Given this list of marker genes Dync2i1, Col1a1, Ccn3, Hapln3, Barx2 (NCBI Gene Id 69472), Bglap, Pax7, Zfp219, Runx2, Ddrgk1, Idua, Nfia, Ext1, Fgr, Slc39a3, Evc, Col3a1, Trip11, Frem1, Mdfi, Mkks, Chadl (chondroadherin-like), Wnt2b, Rarb, Comp, Col5a2, Dll3, Hoxa11, Gdf2, Tulp3, Myf5, Col2a1, Cytl1, Hmga2, Mia3, Anxa2, Rara, Thbs1, Cdx1 (NCBI Gene Id 12590), Hoxb3, Axin1, Il17f, Fst, Cldn18, Hotair (NCBI Gene Id 100503872), Gli3, Pth, Slc9b2, Hoxa10, Cbs, Pappa2, Hapln4, Tgfb1, Hoxa1, Ptger4, Chad, Bglap2, Sgpl1, Eya1, Ggcx, Dlx1, Ski, Chrdl2, Pth1r, Bmpr2, Gpr68, Efemp1, Msx1, Hexb, Ppargc1b, Smad3, Thra, Pbxip1, Nipbl, Pdgfa, Sbds, Schip1, Plxnb1, Atg9a, Srf, Kat2a, Foxn3, Hoxd3, Osr1, Ift25, Creb3l2, Opa3, Bmpr1a, Six2, Mir188, Norad (non-coding RNA activated by DNA damage), Lipa, Thrb, Siglec15, Cer1, T, Ddr2, Sp3, Prrx1, Cyp26b1, Ihh, Atp6ap1, Ccn1, Adamts7, Lep, Nodal, Bmncr, Ltbp3, Men1, Lrrk1, Pbx1, Ebp, Rbp4, Nfib, Fgfrl1, Glg1, Trpv4, Ranbp3l, Rab33b, Ptprc, Wnt9b, Hdac4, Nfix, Itgb6, Gnaq, Recql4, Dscaml1, Obox2, Sik3, Ash1l, Wnt5a, Rflnb, Shox2, Slc39a14, Fmn1, Satb2, Arid5a, Map2k6, Hoxc8, Ncan, Alx4, Sulf2, Tapt1, Stc1, Snx19, Sema4d, Prkg2, Sh3pxd2b, Hoxb4 (homeobox B4), Hoxb9, Tbx3, Deaf1, Bbs2, Wfikkn1, Hyal1, Hoxb8, Ccn2, Flvcr1, Frzb (NCBI Gene Id 20378), Pitx1, Smad5, Fgfr1, Timp3, Hoxd12, Rpl13-ps6, Fgfr3, Hoxd11, Sulf1, P2rx7, Rdh10, Slc39a1, Prrx2, Fosl2, Osr2, Sfrp1, Etl4, Lrrc17, Nr5a2, Hspg2, Nle1, Rpl38 (ribosomal protein L38), Npr2, Papss2, Cyp27b1, Mapk11, Zic1, Ripply1, Myc, Psen1, Timp1, Lnpk, Hes5, Mapk14, Hsd17b7, Myoc, Hoxb2, Dlx5, Slc38a10, Rassf2, Bbx, Cnmd, Tmem38b, Tle5, Chst11, Mapk3, Foxc1, Tbx15, Bbln, Mmp2, Insig2, Dchs1, Mks1, Hoxd8, Zmpste24, Sfrp2, Setdb1, Gna11, Mir140, Hoxa2 (homeobox A2), Tnfsf11, Akap13, Ppib, Clec3b, Fgf8, Tfap2a, Fbxw7, Prpsap2, Col1a2, Col6a1, Pax1, Hoxa6, Eif4a3l2, Sox11, Tgfbi, Alpl, Mboat2, Gdf5, Dhrs3, Bmp1, Mef2d, Obox3, Trp53, Hexa, Pkdcc, Tgfbr1, Spef2, Nppc, Hoxc9, Chaserr, Rgn, Smad2, Nkx3-2, Mepe, Sox9, Trim45, Notum, Lama5, Sox6, Chd7, Rflna, Hoxc11 (NCBI Gene Id 239679), Arid5b, Lncpint, Tmem119, Fbn2, Tyms, Mmp14, Nog, Hoxa5, Tgfb2, Mycn, Fuz, Lrp5, Errfi1, Ctc1, Scube2, Snai2, Bmp8b, Cst5, Acvr2a, Obox1, Med12, Npr3 (natriuretic peptide receptor 3), Ctnnb1, Bmp7, Lrp6, Miga2, Esrra, Acan, Fgf4, Tgfb3, Ift80, Smad7, Trappc2, Wfikkn2, Rarg, Actn3, Usp1, Gli2, Dym, Lepr, Inppl1, Hoxd1 (homeobox D1), Vdr, Has2, Spns2, Ryk, Poc1a, Snai1, Kdr, Ifitm5, Gpld1, Foxc2, Prkca, Chrd, Serpinh1, Obox8, Gnas, Alx3, Ryr1, Zfp950, Tifab, Sp5, Notch2, Xylt1, Hyal3, Bpnt2, Col27a1, Dicer1, Atg9b, Gdf11, Tgfbr2, Ndst1, Cr2, Mosmo, Zic3, Asxl1, Thbs3, Tnn, Fgf6, Pafah1b1, Bcan (brevican), Cadm1, Trp63, Mdk (midkine), Csgalnact1, Dlx1as, Gdf6, Setd2, Bmp2, Wnt7b, Epyc, Wnt9a, Tcf15, Ext2, Slc26a2, Rhoa, Csrnp1, Rpl13, Wnt7a (wingless-type MMTV integration site family, member 7A), Jag2, Loxl2, Ctsk (NCBI Gene Id 99590), Mmp16, Matn3, Dspp, Mef2c, Mcph1 (microcephaly, primary autosomal recessive 1), Fat4, Hoxb5, Pdgfc, Mgp, Fgf2, Tiparp, Obox7, Wnt10b, Slc2a10, Rela, Hif1a, Snx10, Hhip, Ogn, Fbln5, Uncx, Acd, Ltf, Smpd3, Twist2, Col13a1, Mbtd1, Hand2, Grem1, Acp5, Map3k7, Bmp4, Hes7, Ninj1, Pkd1, Ccdc154, Ankrd11, Fam20c, Ostn, Tmem107, Chsy1, Bnc2, Alx1, Cacna1s, Bmp10 (NCBI Gene Id 12154), Ift140, Col18a1, Shh, Acvr2b, Vkorc1, Ghrl, Fgfr2, Dlx2 (NCBI Gene Id 99330), Itgb8, Pls3, Axin2, Enpp1, Plekha1, Dnm3os, Phospho1, Sp1, Zfand5, Cdk20, Mthfd1l, Fancb, Scin, Twist1, Sparc, Pum2, Cited2, Ptpn11, Ano6, Ednra, Col10a1, Hoxa9, Bglap3, Nfatc2, Mex3c, Col11a2, Zbtb7a, Bmpr1b, Hoxc6, Hyal2, Wnt1, Hoxa3, Phex, Wwox, Hapln2, Hapln1, Trps1, Rb1, Wdr48, Bmi1, Dlx4, Ucma, Cdkn1c, Col9a1, Fgf18, Dmd, Otor, Insig1, Lhx1, Fbn1, Hoxd4, Serp1, Hsd17b1, Smad1, Megf8, Bmp3, Atp7a, Gja1, Ecm1, Rab23, Bmp8a, Gas5, Matn1, Six1, Sfrp4, Mbtps2, Hoxd10, Tjp2, Zbtb16, Large1, Dmrt2, Galnt3 (polypeptide N-acetylgalactosaminyltransferase 3), Lgals3, Edn1, Gsc, Foxp1, Hoxb6, Ror2, Bbs1, Pds5a, Gas1, Atf2, Ripply2, Hoxa4, Zfp640, Ift172, Pthlh, Hoxb1, Prkra, Lox, Eif4a3, Slc35d1, Neurog1, Maf, Smad9 (SMAD family member 9), Obox5, Srd5a2, Src, Eng, Gdf3 (growth differentiation factor 3), Ep300, P3h1, Amer1, Slc10a7, Bgn, Optc, Dlx6, Pcgf2 (polycomb group ring finger 2), Hoxc4, Dlk1, Tyrobp, Vcan, Rspo2, Pdgfrb, Igf1, Mir2861, Asxl2 (ASXL transcriptional regulator 2), Cfh, Hoxa7, Mkx, Pax5, Hoxc10, Fbxw4, 2610005L07Rik, Obox6, Sox5, Gata3, Hoxb7, Eif4a3l1, Hoxd13 (homeobox D13), Pex7, B3glct, Nab2, Snorc, Vegfa, Irx5, Rai1, Grhl2, Adamts12, Msx2, Por, Wnt11, Scx, Six4, Carm1, Hoxd9, Wdr19, Fgf9, Tbx1, Zeb1, Eif2ak3, Tgm2, Epha2, Runx3, Hand1, Hoxc5, Twsg1, Bmp6, Pitx2, Dlx3, Runx1, Tbx4, Hottip, Wdr5, Gja5 (NCBI Gene Id 70659), Mmp13, Nsd2, Ttc9, Mustn1, Nab1, Acp2, Bmp5, Mmp9, Pcsk5 (proprotein convertase subtilisin/kexin type 5), Dlg1, Col11a1, Ccn4, Pdgfra, here is a description of the gene set: studied in species Mus musculus The process whose specific outcome is the progression of the skeleton over time, from its formation to the mature structure. The skeleton is the bony framework of the body in vertebrates (endoskeleton) or the hard outer envelope of insects (exoskeleton or dermoskeleton). Mouse Gene Set: GOBP_SKELETAL_SYSTEM_DEVELOPMENT